The following is a description of a gene set: Human Gene Set: GENTILE_UV_RESPONSE_CLUSTER_D9 species: Homo sapiens from publication Gentile M, Latonen L, Laiho M (PMID 12907719) Cluster d9: genes progressively down-regulated in WS1 cells (fibroblast) through 24 h after irradiation with high dose UV-C. DNA damage caused by UV radiation initiates cellular recovery mechanisms, which involve activation of DNA damage response pathways, cell cycle arrest and apoptosis. To assess cellular transcriptional responses to UVC-induced DNA damage we compared time course responses of human skin fibroblasts to low and high doses of UVC radiation known to induce a transient cellular replicative arrest or apoptosis, respectively. UVC radiation elicited >3-fold changes in 460 out of 12,000 transcripts and 89% of these represented downregulated transcripts. Only 5% of the regulated genes were common to both low and high doses of radiation. Cells inflicted with a low dose of UVC exhibited transcription profiles demonstrating transient regulation followed by recovery, whereas the responses were persistent after the high dose. A detailed clustering analysis and functional classification of the targets implied regulation of biologically divergent responses and suggested involvement of transcriptional and translational machinery, inflammatory, anti-proliferative and anti-angiogenic responses. The data support the notion that UVC radiation induces prominent, dose-dependent downregulation of transcription. However, the data strongly suggest that transcriptional repression is also target gene selective. Furthermore, the results demonstrate that dose-dependent induction of cell cycle arrest and apoptosis by UVC radiation are transcriptionally highly distinct responses., and this is the list of marker genes: ADM, TMEM97, TGIF1, CITED2, NAP1L1, DYRK2, HOXB6, RBPJ (recombination signal binding protein for immunoglobulin kappa J region), CCSER2, ACVR1B, RRS1, TRIM32, CCNG1, IST1, KIAA0232, DNAJB1, CCNA2, IDI1, PALM2AKAP2, UBR5, AGTR1, PRRC2C, KLF9, SWAP70, CD2AP, LPCAT1